The following is a description of a gene set: part of: Signaling by TGFB family members electronically inferred by orthology from the curated human pathway Reactome Pathway: Signaling by TGFBR3 This event has been computationally inferred from an event that has been demonstrated in another species.<p>The inference is based on the homology mapping from PANTHER. Briefly, reactions for which all involved PhysicalEntities (in input, output and catalyst) have a mapped orthologue/paralogue (for complexes at least 75% of components must have a mapping) are inferred to the other species. species: Mus musculus, and this is the list of marker genes: Mmp14, Gipc1, Inhba, Fgf2, Psen1 (presenilin 1), Arrb2, Psenen, Timp1, Tgfb1, Acvr2a